Given this list of marker genes Col6a1, Col2a1, Col1a2, Pdgfrb, Col5a1, Col4a1, Pdap1, Pdgfa, Col1a1, Pdgfb, Col3a1, Pdgfra, here is a description of the gene set: species: Mus musculus Mouse Gene Set: GOMF_PLATELET_DERIVED_GROWTH_FACTOR_BINDING Binding to platelet-derived growth factor.